Given this list of marker genes Gimap5, Carmil2, Lgals9, Foxp3, Dusp10, Ctla4, Lilrb4a, Lck, Tgfb1, Btn2a2 (NCBI Gene Id 238555), Il2rg, Pla2g2d, Kat5, Ifng, H2-Ea, Dicer1, Lilrb4b, Cd28, Ambra1, Tox, Il4i1, Cd46, Ncor1, Cd44, Hspb1, Bcl6, Mdk, Ctla2a, Socs1, Kat2a, Klhl25, Fanca, Vsir, Il2 (NCBI Gene Id 16183), Fut7, Gimap3, H2-M3, Sox12, Foxo3, Usp44, Lag3, Tnfsf4, Kcnk18, Fancd2, Irf1, Drosha, Sh2b3, here is a description of the gene set: The process in which a relatively unspecialized T cell acquires specialized features of a regulatory T cell. Regulatory T cells control or suppress immune responses through a variety of mechanisms and subsets include the CD4+CD25+ cell type as well as certain CD8+ cell types. Mouse Gene Set: GOBP_REGULATORY_T_CELL_DIFFERENTIATION species: Mus musculus